Given this list of marker genes SOCS1, DPYS, VPS33A, COL6A1, MT-TL1, CPOX, HPS6, TKT, ACE, GCDH, SRCAP, PRKAR1A, ADA, CAMKMT, IGHG2, PRMT7, LAMA5, SLC2A9, STAT2, F9, BANK1, IL12A-AS1, LZTFL1, VPS37D, KIRREL1 (NCBI Gene Id 55243), DDC, ABCC6 (NCBI Gene Id 5823), DCDC2, ALG1, EMP2, CD2AP, NRAS, TTR, MAGED2, BNC2, STAT5B, BCR, TBX1, INPPL1, LETM1, UBAP2L, SATB1, CFHR3, C3, ITPR3, LMAN1 (lectin, mannose binding 1), SLC1A1, STX1A, LIPN, HCFC1, ECHS1, GP1BA (NCBI Gene Id 2811), ACBD6 (NCBI Gene Id 84320), MAD2L2, DNMT3A, SGSH, PKHD1, CFB, TSC2, NFS1, FGF23, SLC16A1 (solute carrier family 16 member 1), BTD, PCBD1, CEL, TCF4, SCO1, SALL1, YRDC, GAMT, MAX, BBS9, NDUFB3, IFT122 (NCBI Gene Id 55764), SDHA, IL2RB, BLM, PIGB, UQCC2, CTH (cystathionine gamma-lyase), GNPTAB, ADNP, ITGAM (NCBI Gene Id 3684), CASP10, PIK3CA, CREBBP, CFHR1, HNF4A, MMAA, WIPF1, PRDX1, GNAS, MT-ND3, PBX1, KCNJ1, NSMCE2, AGTR1, CHD4, CDKN2B, CDK4, LDHA, PEX14, RRM2B, LCAT, DKC1 (NCBI Gene Id 1736), CNNM2, MT-ND1, OPLAH, PYGM, IL23R, PEPD, GATA3, NUP93, SLC12A3, LPIN2, COG6, FARSB, CEP120, LPIN1, POLG, ZAP70 (NCBI Gene Id 7535), SLC26A1, MYOCD, XIAP, DYNC2I2, ATP11C, TBC1D24, LDHD, HADHB, MINPP1, NDUFAF5, TREX1, FAN1, GP1BB, DNAJB11, FOXP2, CTNNB1, GLYCTK, STAT1, TBL2, VHL (von Hippel-Lindau tumor suppressor), FKRP, ALDOA, HSD17B10, IQCB1, ATRX, NDUFV2, CHST14, NDUFAF6, ALG5, DPYD, MOCS1, RET, IL2RG, IDH1, SOX18 (NCBI Gene Id 54345), TP53, MT-CO2, TEFM, PHEX, MEFV, ALOXE3, DNASE1, SLC28A1, RAD51C, SLC19A2, ATP5MK, PIK3C2A, EXT1, HSD11B2, LIN28B, TMEM70, LRIG2, HMGCL, MT-ND4, KCNJ16, TMEM260, REST, EBF3, ARG1, LARS2 (NCBI Gene Id 23395), CEP164, ERCC3, GATA6, F8, PREPL, TBK1, KAT5, ATP5F1A, ASPRV1, FCGR2B (Fc gamma receptor IIb), HAL, TP53RK, FANCB, FDFT1, BLVRA, TMEM237, KIAA0753, STS, ITGB4, MYL9, ITGB3, ITGA3, MT-ATP8, FXYD2, SLC30A9, PTPN22, LAMA3, ANLN, IL1B, FANCC, GCM2, CRB2, FGA, CYP27B1, F2, MIF, LACC1, TPRKB, BBS10, POU6F2, NDUFS3, GEMIN4, SURF1, STX11, GABRA3 (NCBI Gene Id 2556), CYP21A2, NPM1, NIPAL4, INSR, STX16, AP2S1, MAPKBP1, BTK, COQ8B, IL17RA, CCR1, TAFAZZIN, COQ4, NDUFAF2, EP300, TRPV6, SCO2, THOC6, EIF4H, SLC46A1, BBS1, OCRL, SDHAF2, MARS1, MYD88, IL7R, WDR35, PAX6, NT5C3A, RNU7-1, UNC13D, F5, KHK, DOCK11, IFT74, TLR7, RARA, NEUROD1, FIP1L1, FAM20A, MYH9, OXCT1, HADHA, FH, TMEM127, SLC5A1, DMGDH, BBIP1, PALB2, TAT, LTBP1, SLC4A2, GTF2IRD2, DIS3L2, NDUFA6, SAMD9, PGM3, ZNFX1, COX16, MIA3, ZBTB16 (zinc finger and BTB domain containing 16), XPA, INF2, HMOX1, DHDDS, APOL1, HNRNPK, KYNU, D2HGDH, TAPBP, MT-TT, TBL1XR1, POLRMT, TMEM231, ALAD, NDUFS1, COL4A5, XPNPEP3, PHYH, FMO3, MT-CO1, MT-CO3, BAZ1B, GLB1, INS, XPC, WDPCP, SLC52A1, MMAB, TRPV4, TRMU, CC2D2A, P4HA2, LMNA, SREBF1, C1QA, WDR73, CLTRN, ROBO1, KCNJ5, HMBS, COL4A4, DACT1, SIX1, PPOX, EYA1, C1QBP, GALNS, HGSNAT, FANCL (NCBI Gene Id 55120), COQ2, NCF2, CPT1A, ARNT2, MST1, NDUFB10, SLC26A4, TRAF3IP2, TNFRSF11A, COL4A1, MDM2, AVPR2, ARSB, RFWD3, WT1, SERPINF2, COL2A1, TRIM28, HOGA1, UQCRB, GRHPR, TMEM126B, PDP1, ARL6, COL4A3, SOX17, ITGA2, PCCB, ABCC2, CFTR, COQ6, SHPK, ACAT1, BRCA2, PHOX2B, PLVAP, PFKM, PRF1, FANCD2 (NCBI Gene Id 2177), TMEM165, CIITA, LAMB3, GON7, PRODH, NDUFS8 (NADH:ubiquinone oxidoreductase core subunit S8), FLAD1, GSN, TANGO2, MRAP, CRPPA, AKR1D1, NTRK1, IDH2, WDR19, CD320, CDKN1A, RASA1, DPH1, PRKCD, DDB2, SCAPER, WWOX, CISD2, MRPS2, ADA2, CLEC7A, PTPRO, ANKS6, CLIP2, PLG, SDHB, NUP133, AMMECR1, MTHFR, ACP5, HDAC8, UBAC2, PIK3CG, ATP5F1D (NCBI Gene Id 513), VIPAS39, SNX14, PC, CEP290, ADSL, CASR, ALMS1, BCOR (NCBI Gene Id 57686), MAPK1, RAG2, ZNF699, INPP5E, LYZ, NEK8, SLC25A11, SLC41A1, EFEMP2, ERBB2 (NCBI Gene Id 2064), GNA11, ATP7A, ABCD4, FAH, NBN, SMC3, EN1, IVD, GALK1, IL1RN, PNP, HTRA2, MCCC2, CPT2, SON, VPS33B, ALDOB, BRIP1, AMN, SLC35C1, NSD1, FN1, SKIC3, CACNA1S, IL17F, IGKC, CCN2, SLC22A5, SUGCT, CORIN, SOX9, BRCA1 (NCBI Gene Id 672), OFD1, ANKFY1, ARSK, FOXC2, SERPINA1, PEX12, DBH (NCBI Gene Id 1621), HMGA2, ATP7B, SLC34A1, IL12A, MRPL39, ZNRF3, DCLRE1C, FGFR2, MPC1, DLD (NCBI Gene Id 2654), NDUFAF4, DAAM2, BBS4, TTC21B, LIPT1, EPG5, LIG4, KRT18, NABP1, ETHE1, MT-TH, NOS1AP, CHD7, MEN1, PXK, TIMM50, TBX18, DHTKD1, G6PC1, CYP24A1, FLT1, SLC2A2, CLCN5, CSPP1, SERAC1, CAD (NCBI Gene Id 790), CCR6, HLA-DPA1, ALG9, DLST, ATP6V0A4, NOD2, IER3IP1, GLDC, AGK, ATP5F1E, ABCA12, NHERF1, FANCG, HRAS, SH2B1, GTF2IRD1, ZMYM3, SLC25A15, CD81, SLC5A2, NUP205, CDKN2C, FASLG, STIM1 (stromal interaction molecule 1), NUBPL, NDUFS7, OPA3, GPC3, SLC6A19, GNAS-AS1, SLC12A1, MAN2B1 (mannosidase alpha class 2B member 1), OXGR1, NDUFA11, STX3, ZFPM2, AHI1, PHKG1, SDR9C7, NUP107, FBLN5, NIPBL, ATAD3A, PML, HPSE2, KIF1B, NAGA, SLC7A7 (solute carrier family 7 member 7), TMEM138, NUP160, DYRK1A (NCBI Gene Id 1859), HBB, IL36RN, PTH1R, TRAIP, SLC13A3, WFS1, CTLA4, COPA, SMC1A, KANK2, TXNRD2, GLUD1, SLC3A1, CDC73, ALDH18A1, GGT1, SPTBN1, PEX5, CHRNA3, KCTD1, FOXI1, EIF2AK3, TRAF3IP1 (TRAF3 interacting protein 1), TBC1D8B, NPR2, UMPS (uridine monophosphate synthetase), ISCU (NCBI Gene Id 91850), PPM1B, APRT, ABCB7, MT-ND5, CD109, SLC25A19, FOCAD, CLDN19, NPHS1, FOXN1, YAP1, IFT27, MAF (MAF bZIP transcription factor), MCCC1, SNAP29, PAX2, GATM, PSTPIP1, ARPC5, STK11, HOXA13, ATP6V1B2, CDKN1B, HPRT1, TMEM270, PEX1, ASPH, PNPLA6, POLR3GL, TDO2 (tryptophan 2,3-dioxygenase), LMNB2, MUTYH, ALK, TERT, NPHP1, XRCC2, APC2 (APC regulator of WNT signaling pathway 2), OBSCN, SLX4, LMX1B, LMBRD1, MT-TK, HLA-DPB1, MUC1, XDH, HNF1A, LHX1, ANO5, MANBA, SLC25A20, RAD21, KLRC4, MTRR, PIK3CD, PAFAH1B1, CFI, MME, C4B, REN, GP9, CA2, PDX1, MAP3K1, KLF6, PCCA, JAK2, GALT, GATA4, NOS3, EPAS1, WAS, HLCS, PLCE1, MT-TS2, MC2R, WASF1, RPGRIP1L, KDM6A, IGHG1, UBE2T, FUCA1, KNSTRN, FANCI, KMT2D, FAS, DDOST, CD59, XYLT1, DGKE, IFNGR1, CD151, ACSL4, ELP1, PKDCC, MLXIPL, NAGLU, IRAK1, HACE1, FANCF, ABCC8 (ATP binding cassette subfamily C member 8), CCNQ, MMUT, SLC25A4, ARHGAP24, H19, FBP1, PKD2, MYO1E, ACADVL, NDUFAF1 (NADH:ubiquinone oxidoreductase complex assembly factor 1), TRPS1, FUZ, CFAP418, DMP1, JAZF1, F10, RMRP, HPD, SULT2B1, NPHP3, CHRM3, SLC17A5, GALE, IKZF1, RFC2, SPRY2, NR0B1, PIEZO1, MVK, GNPTG, IFT56, NAE1, ACAD9, INVS, BBS12, SUOX, CFHR5, STAT3, KCNJ2, NFU1, ACTN4, ELN, DNAJC30, MYH11, PHKG2, NGLY1, HNF1B, TRIM8, MMADHC, MT-TV, ACADS, TRIP13, HADH, CTNS, KANSL1, COX14, PCK1, UROC1, ENPP1, ASL, NCF1, CPS1, EHHADH, CYP27A1, BCS1L, UROS, MKS1, SCNN1A, PKD1, OTC, PHYKPL, HIC1, ACSF3, JAK1, MECP2, RAD51, CLCNKB, CHUK, TLR4, ATP1A1, TCN2, TMEM216, GUSB, LMNB1, GNE, CRKL, ACADSB, PAX4, CLPB (ClpB family mitochondrial disaggregase), IRF2BP2, TNFAIP3, PIGA, SMARCAL1, TNFRSF11B, DYNC2LI1, IFNG, CALR, AQP2, TAOK1, SLC34A2, SLC6A2, CYBC1, SLC35A1, THBD, SLC22A12, ACAD8, KIF23, PIGT, PHKB, VAMP7, FBXL4, COL3A1, PEX7, CA5A, FTCD, HLA-B, TGM1, DNASE2, NLRP3, MED12, XYLT2, GLIS2, TAF6, HMGCS2, ERCC5 (NCBI Gene Id 2073), PLOD2, IFT172, IFT140, PHKA1, CCND1, CYC1, PYGL, SPP1, GPHN (NCBI Gene Id 57566), MOCOS, APPL1, MT-TF, C1GALT1C1, MT-ATP6, PUS3, GK (glycerol kinase), NDUFA1, SLC37A4 (NCBI Gene Id 84965), GCH1, AGXT2, MAFB, BRD4, PGAM2, ITGA8, DNAJC19, CLDN10, GYS2, SLC4A4 (solute carrier family 4 member 4), GSS, APOE, HELLPAR, FLVCR1, CD46, UPB1, DZIP1L, TMEM67, RELB, BBS5, TAMM41, NADK2, IL6, BTNL2, ALPL, MMP1, GAPVD1, COA8, MTR, KL, CR2, HSD3B2, SLC25A13, FOXP3, TNFSF4, PGK1, NUMA1, NDUFB11, TRIM32, OAT, PEX19, FARS2, ALDH5A1, ASPA, SERPINA6, TPK1, LIMK1, SLCO1B3, SLC25A21, ZNF592, ATPAF2, LRP2, IFIH1, SLC36A2, STOX1, UMOD, LMO1, NDUFAF3, TIMMDC1, BSND, HPS1, FCGR2A, MT-TW, STAT4, B2M, NUP37, SDHC, TFAM, AUH, BLK, VANGL1, KCNJ18 (potassium inwardly rectifying channel subfamily J member 18, NCBI Gene Id 100134444), SLCO1B1, PDSS2, WDR4, NNT, ALOX12B, TNIP1, COG1, SLC7A9, AVIL, ALDH6A1, EXT2, MCFD2, SDCCAG8, C4A, GANAB, SLC35A2, MOCS2, CASK, L2HGDH, KAT6A, MT-ND6, ZMPSTE24, NEXMIF, MLIP, FDX2 (NCBI Gene Id 2143), HIBCH, NPHS2, ARL3, SARDH, CDC42BPB, ETFA, IRF5, IFT80, RMND1, SLC6A20, PRTN3, MT-ND2, GAA, HSPA9, ATP6V1B1, GTF2I, KIAA0586, SLC34A3, CUBN, PDCD1, ZNF423, HEXB, CAV1, SCLT1, PET117, GPR35, NDUFS6, SEC61A1, IBA57 (iron-sulfur cluster assembly factor IBA57), MCEE, MSN, CYP11A1, ITGA6, DYNC2H1, GBA1, TRMT5, IL10 (NCBI Gene Id 3586), SLC16A12, OGDH (NCBI Gene Id 4967), KLF11, GUCY2D, LYRM4, SIX5, IDUA, SGPL1, ITGA2B, CLCNKA, CYB561, SMAD4 (SMAD family member 4), UBE2L3, UNC45A, SEMA4D, CLDN16, OSGEP, NDUFV1, MKKS, AGGF1, ETS1, CYP2R1, DCXR, CBS (NCBI Gene Id 875), NPHP4 (NCBI Gene Id 261734), BBS2, FKBP6, TTC8, ARHGDIA, IFT43, PMM2, VPS50, TP63, GATA1, GCK, GCLC, HLA-DRB1, FCGR2C, OCLN, TK2, BUD23, GALNT3, ERCC4, NDUFS4, SDHD, KCNJ11, NDUFA9, BICC1, CFH, ETFDH, PHKA2, KRAS, ETFB, MT-TN, ISL1, KCNE5, CYP4F22, ERCC6, MICOS13, FANCM, SLC52A2, APC, CDKN2A, TGFB1, MTX2, NDUFS2, ERCC8, LRPPRC, HSPD1, POLR3A, UROD, DGUOK, CEP19, CYP11B1, CEP83, G6PC3, SUMF1, ERAP1, DYNC2I1, MPV17, ALDH4A1, SCNN1G, MLYCD, KCNJ10 (potassium inwardly rectifying channel subfamily J member 10), JAG1, AGA, NF1, SLCO2A1, SFXN4, DNASE1L3, DHX37, PGM2L1, SUCLA2, LAGE3, MAGI2, APOA1, FCGR3B, VAC14, ADAMTS13, DSTYK, DLG5, SCNN1B, SLC18A2, KARS1, AASS, NOP10, AP1S3, METTL27, FANCA, SARS2, PRPS1, CDKN1C, RAG1, ADCY10, IL17RC, SLC6A8, LAMB2, RRAGD, AGT, NUP85 (NCBI Gene Id 83705), ACVR1B, FIG4, FOXRED1, NR5A1, STXBP2, SRY, MT-TQ, TSC1, SLC4A1, RYR1, MYCN, ASS1, SGCB, ERCC2, EHMT1, MMACHC, MPI, FANCE, GNS, YWHAE, RPIA (NCBI Gene Id 22934), ATIC, MNX1, NDUFAF8, DMD, PET100, SCARB2, LAMC2, SPINK5 (NCBI Gene Id 50962), CYP11B2, MYO5B, HGD, IRF1, NOTCH2, YY1AP1, STAR, COL4A6, G6PD, SUCLG1, MDH2, AGXT, IDS, GLA, SMARCA2, NEU1, SAT1, TRPC6 (NCBI Gene Id 7225), NDUFB9, KIAA0319L, SLC25A1, SLC6A18, BBS7, COL7A1, PAH, TNXB, ACADM, SAA1, TRNT1, PLOD1, BCKDHA, here is a description of the gene set: studied in species Homo sapiens Abnormality of the urinary system physiology Human Gene Set: HP_ABNORMALITY_OF_THE_URINARY_SYSTEM_PHYSIOLOGY